Given this list of marker genes Tuba1a, Fmr1, Ube3a, Myg1, Crh (NCBI Gene Id 383938), Apoe, Dlg4, Tnr, Gad1, Shank3, Slc4a7, Crhr1, Lrrk2, Prkce, Crbn, Lsamp, Dpp4, Penk, Grn (granulin), Atp1a2, Slc4a10, Nlgn2 (NCBI Gene Id 216856), here is a description of the gene set: Mouse Gene Set: GOBP_LOCOMOTORY_EXPLORATION_BEHAVIOR studied in species Mus musculus The specific movement from place to place of an organism in response to a novel environment.